The following is a description of a gene set: from publication Yevshin I, Sharipov R, Kolmykov S, Kondrakhin Y, Kolpakov F (PMID 30445619) studied in species Homo sapiens Human Gene Set: YBX1_TARGET_GENES Genes containing one or more binding sites for (YBX1) in their promoter regions (TSS -1000,+100 bp) as identified by GTRD version 20.06 ChIP-seq harmonization., and this is the list of marker genes: HOXD11, BRD7, CHD5, AHRR, MT-TP, POMP, TMEM277P, ZNF18, YIF1B, CASP6 (NCBI Gene Id 839), GUCY1A1, BTN2A2, PTPN13, KCNT1, TRAJ28, DDX17, NOP53-AS1, RBBP6, KCNN4, EEF1A1, SLC7A8, ZNF233, IL6ST, SNORD55, MAPK10, MSL3, SEPTIN8 (NCBI Gene Id 23176), EPC2 (NCBI Gene Id 96643), SRSF10, CLIC2, GTF2A1-AS1, EFHB, RNA5SP453, SLAMF1, CASP7, NECAB2, AACS, TSC22D4, SLC7A1, CD37, RIMBP3, NEUROG2, TRPM4, MUC12-AS1, CLSTN3, MARK4, SLC22A7, PKM, ZC3H14, ARHGEF1, FSCN2, GLB1L3, MLPH, DGLUCY, CHD4, AGPAT5, PAFAH1B1, FDXACB1, RNVU1-32, CBX3, TNNT3, ENSG00000273582, CEP95, CUEDC2, CFAP68, MLEC, DDX5, TMC6, UQCC1, GABARAP, PTAFR, ZNF773, RPS8, ASAP1, CES5AP1, HNRNPA2B1